The following is a description of a gene set: Human Gene Set: GOBP_INTRINSIC_APOPTOTIC_SIGNALING_PATHWAY The series of molecular signals in which an intracellular signal is conveyed to trigger the apoptotic death of a cell. The pathway starts with reception of an intracellular signal (e.g. DNA damage, endoplasmic reticulum stress, oxidative stress etc.), and ends when the execution phase of apoptosis is triggered. The intrinsic apoptotic signaling pathway is crucially regulated by permeabilization of the mitochondrial outer membrane (MOMP). studied in species Homo sapiens, and this is the list of marker genes: MARCHF7, TNFRSF10B, CUL5, POU4F1, UBQLN1, TNFRSF1B, CREB3L1, PLAUR, NBN, PHLDA3, CASP4, ITPR1, MSX1, ZNF385B, HIC1, S100A8, CYP1B1, BCL2L2, TOPORS, DDX3X, BCL2L10, RNF186, BAD (BCL2 associated agonist of cell death), BID, HSPB1, FBXO7, SELENOK, E2F1, FBH1, CYCS, BCL3, SIRT1, PTPMT1, MIR195, NONO, TRIB3, ATP2A1, TMBIM6, MIR92A1, ABL1, GSDME, SOD2, NOC2L, CXCL12, OPA1, TP63, ZNF622, MCL1, MAP2K1, MAPK8IP1, EIF2AK3, PTPN2, BBC3, INS, EIF5A, CUL3, FLCN, PIAS4, PRKN, MAEL, RACK1, CHEK2, PARL, MLLT11, MIR15A, CUL4A, CD44, PPP2R5C, PTGS2, WNT1, PDK1, APP, TP53BP1, SFRP2, MSH6, P4HB, MIR16-1, HSPE1, FGF2, SFPQ, RRP8, BCL2L1, AKT1, TAF9B, DAB2IP, ERP29, NCK1, STYXL1, TMEM109, IFI27, ARMC10, TP53BP2, DNAJA1, FNIP2, MAPK7, CASP3, FIGNL1, MTCH2, HRAS, MSH2, DDX5, NFATC4, MIR132, SGPP1, WFS1, SOD1, JMY, BNIP3 (BCL2 interacting protein 3, NCBI Gene Id 664), ATP2A3, HELLS, CEBPB (CCAAT enhancer binding protein beta), SCN2A, ARHGEF2, MIR21, BECN1, BAK1, MIR27B, NLRP1, TAF9, STK24, BAG6, HINT1, STK25, TRIAP1, SEPTIN4, NOL3, PRKCD, PRKRA, IL19, EDA2R, BAG5, SELENOS, RPS7, POLB, CASP9, RPL26, IKBKG, RPS27L, CASP6, FYN (NCBI Gene Id 2534), S100A9, TMEM238L, ERO1A, TNFRSF1A (NCBI Gene Id 8077), MMP2, BCL2L12, DYRK2, PML, HIPK2, IFI27L2, DNAJC10, IL10, MOAP1, BAX, LCK, GSKIP, SHISA5, TRAF2, PDCD10, PRKDC, HIPK1, MLH1, PARK7, IFI27L1, IKBKE, IFI6, ERN1 (NCBI Gene Id 63433), CUL1, RNF183, PPIF, ERCC6, CDKN1A, CDKN2D, DAXX, E2F2 (NCBI Gene Id 1870), FCGR2B, IVNS1ABP, CREB3, HNRNPK, TXNDC12 (NCBI Gene Id 51060), MIF, BRSK2, TP73, IFI16, NME5, EPO, TMEM161A, PYCARD, NUPR1, CD74, MYC, BCL2, DDIT4, TPT1, RRM2B, FBXW7, GATA4, DDIT3, BRCA2, MIR133A1, CIDEB, SNAI1, EP300, PYCR1, IER3, PLAGL2, CASP2, MIR186, MIR17, FZD1, MMP9, CTNNB1, USP28, TIFAB, MDM2, CAV1, ADCY10, TRIM32, URI1, ATM, RRN3, SKIL, PPP1R15A, MAP2K4, TREM2, SNAI2, CYLD, CARD8, FIS1, FHIT, LRRK2 (leucine rich repeat kinase 2), COA8, LAPTM5, NKX3-1, PMAIP1 (NCBI Gene Id 9305), PRODH, RIPK3, PERP, ACKR3, BCL2A1, PDX1, BCLAF1, AEN, DDIAS, NHERF1 (NCBI Gene Id 9368), AIFM1, SIAH1, POU4F2, TNF, RPS3, TP53, DIABLO, PARP1, UACA, HIP1R, USP47, UBB, XPA, SRC, CUL2, NACC2, MAGEA3, CDIP1, BCAP31, PPIA, XBP1, BOK, CHAC1, PIK3R1 (phosphoinositide-3-kinase regulatory subunit 1), MIR29B1, TAF6, GPX1, BDKRB2, PIK3CB (phosphatidylinositol-4,5-bisphosphate 3-kinase catalytic subunit beta), ATF4, ELL3, ATAD5, QRICH1, SYVN1, ZNF385A, MIR19A (NCBI Gene Id 406979), RTKN2, ING2, HYOU1, PTPN1, HIF1A, CRIP1 (NCBI Gene Id 1396), KDM1A, SERINC3, MELK, PPP1R13B, HERPUD1, BCL2L11, ERN2, HDAC1, CCAR2, DAPK2, TRAP1, SFN, CD24, TMEM117, USP15, EPHA2, RAD9A, MYBBP1A, VNN1, SNW1, WWOX, LGALS12, ARL6IP5, BRCA1, EI24, NFE2L2, HSPA1A, MAP3K5, ENO1, PINK1, PDK2, CLU, ERCC2, NOX1, NCK2, PTTG1IP, GRINA, JAK2, APAF1, YBX3, MUC1, SIVA1, HTRA2, SGMS1, STK11, IL20RA, ATF2